The following is a description of a gene set: studied in species Homo sapiens The appearance of a cytokine due to biosynthesis or secretion following a cellular stimulus, resulting in an increase in its intracellular or extracellular levels. Human Gene Set: GOBP_CYTOKINE_PRODUCTION, and this is the list of marker genes: LILRA2, SMAD7, TRIM6, PRKD2, TRAF3, MIR100, FFAR2, CD226, MBP, TLR2, TRIL, TLR6, HLA-DPB1, CLNK, NRDC, SIGLEC1, ZBTB17 (NCBI Gene Id 7709), CARD16, GPR65 (G protein-coupled receptor 65), BANF1, PLAGL1, CACTIN, GLMN, MIR28, ARNT, NODAL (nodal growth differentiation factor), HMGB2, MIR19A, CD36, C5AR2, RELB, TYK2, CUL3, MIR302A, PTPN22, OTUD7B, CMA1, GBP1, TRIM15, IFNA2, IL4, TNFRSF21, IRF5, IL36A, FGFR1, ATF2, SCGB1A1, MIR204, ITGB6, CASP3, IFNGR1 (NCBI Gene Id 3459), HRAS, SPHK1, PTPRC, EZH2, CUEDC2, CLU, ARG2, MIR520C, IL2, NFATC4, APOA2, SMAD3, SIGLEC16, DDIT3, GSTP1, ALOX15B, SYT11, FFAR4, IKBKB, CEACAM20, DTX4, KAT2A, LAMTOR5, ILRUN, INAVA (innate immunity activator, NCBI Gene Id 91162), PRKCA, PANX2, RSAD2 (radical S-adenosyl methionine domain containing 2), OSM, POSTN, MIR520B, LRRC19, VTCN1, RARA, CYRIB, MIR185, HEG1, ELF4, MIR203A, NR1H4, TRAIP, MAVS, CD96, RNF216, ZFPM1, DDX1, PTGS2, LRRK2, MIR181D, MIR766, FN1, POMC, MIR26A1, NLRP7, GATA3, ZBTB45, IRAK3, TGFB3, CXCL6, PGLYRP3, ZNF287, EZR, DEFB131A, FCGR2C, KLF4, CARD9, MIR129-1, MIR130A, TICAM2, PANX3, MIRLET7C, NFKBIA, TLR7, RAET1G, BTNL10P, ADCY7, TNFRSF1B, VSIR, BTN2A2, NOS2, TSLP, UCN, MAPK14, PYDC2, LURAP1, CD81, CHID1, CD6, TRIB2, MIR214, TWSG1, NFKBIL1, CYLD, MIR24-1, ARHGEF2, IL17RB, IFNL1, TRIM56, AGT, HLA-DPA1, IRF4, AGER, KLHL22, MIR125B1, ADCYAP1, MAP2K5, BTK, CHRNA7, MIR194-1, MAPK9, ARRDC4, AZU1, NCKAP1L, C1QTNF3, INHA, MIR107, MIR488, ISL1, SMAD4, EIF2AK2, SRGN, RIPK2, CD83, LTF, HK1, HLA-B, AXL, CCDC88B, TRIM65, MIRLET7F1, C3, BMPR1A, S100A13 (S100 calcium binding protein A13), BCL10, TRAF3IP3, XCL1, PRKACA, FCGR2A, TIGIT, CD74, HOMER3, IL36RN, ZBTB14, HDAC3, MIR372, FCGR3A (Fc gamma receptor IIIa), ARRB2, JPH4, CD4, SERPINB1, REL, SPN, PHB1, CALHM6, JAK2, CLC, ZNF572, ARID5A, CREB1, MIR200B, ERBIN, HSPD1, MOG, AKAP8, STAT5B, LILRB1, CD2AP, HSPB1 (NCBI Gene Id 3315), IL6R, IRF8, IRGM, APOD, CGAS, LPL, RNF135, FZD5, TMIGD2, PER1, BST2, LACC1, PRG3, HLA-G, PLD3, IL18R1, RFTN1, AIM2, MIR365A (NCBI Gene Id 100126355), WNT5A, PDE4D, IL23R, FCER1G, MAST2, CD2, TNFSF4, FFAR1, FCGR1BP, IL9, TNFRSF8, SOCS5, GDF2, IL18, HSPA1B, THBS1, GPNMB, CYBA, PGLYRP2, MIR105-1, CD40, IL16, NLRC4, SULF2 (NCBI Gene Id 55959), MIR206, MALT1, IFNG, NLRP9, LGALS9B, PML, TUSC2, NOD2, CARD18, TNF, CRP, MIR146B, TIRAP, HMGB1, SPTBN1, MIR708 (NCBI Gene Id 100126333), LILRB2, LUM, PARK7, BCL6, GBP7, PNP, GATA4, CD200, ZCCHC3, PRKCQ, PELI1, IL1A, MIF, NOD1, GPAM, ACKR1, YY1, TRIM27, KPNA6, NMB, IL37, JAK3 (NCBI Gene Id 3718), SCAMP5, CEACAM1, MAPKBP1, FURIN, PIK3R1, HTR2A, USP22, IL5RA, IL33, MIR20A, F11R, PPP1R11, EBI3, CRLF2, NDFIP1, CCL19 (NCBI Gene Id 6363), HTR2B, ADIPOQ, EPHA2, ATF4, MIR149, HMSD, BCL6B (NCBI Gene Id 7613), IL17A, PLA2G3, IRAK1, WNT3A, TICAM1, MIR200C, UFSP2, MIR93, CRTAM, NR4A3, MIR34A, POLR3G, C1QBP, CLEC12A, ACE2, RIPK3, LEF1, PYDC1, IL1R2, BTN2A3P, TGFB2, BANK1, ZNF131, CD24, MIR411, UAP1, HSPA1A (NCBI Gene Id 3303), FLOT1, C5AR1, QKI, ANGPT1, TOMM70, ASB1, F2, ABCD2, ARG1, POLR3C, CCBE1, MIR145, ADRA2A, MEFV, CD160 (NCBI Gene Id 11126), MYD88, ZBTB25, NLRP2, MIR215, LRRC32, INHBA, SASH3, RIGI, OTUD5, HAVCR2, ITCH, GPR18, KLRK1, ZBTB32, LGR4, IGF1, LAPTM5, XBP1, IFIH1, NMBR, CXCL17, FOXJ1, CASP8, CCR2, CLEC5A, CRYBA1, BATF, MIR338, LEP, MIR29B1, NLRP12, IL13, PIK3CG, BCL3, TYROBP, CD28, FFAR3, RTN4, EIF2AK3, CD55, PLCG2, POLA1, KAT8, NFAM1, ZBTB7B, HDAC9, MIR106A, NOX5, TMF1, FGR, NPLOC4, AGPAT2, MIR205, LTB, NLRP6, DEFB114, TLR4 (toll like receptor 4), ZC3HAV1, LGALS9, CSF1R, CCR7, DENND1B, IL1RL1, IL1R1, NOX1, BTN1A1, SCIMP, PTPN6, ZBTB26, IL1RAP, ZBTB33 (zinc finger and BTB domain containing 33), NMI (NCBI Gene Id 9111), TRAF3IP1, NLRP2B, ADORA2B, STAT1, LTA, SCRIB, MAPK13, ARRB1, BTN3A1, IGF2BP3, NAIP, HLA-E, BTN3A2, RPS6KA4, LY9, ISG15, PYCARD, DEFB124, PTPRS, CHIA, SIRT1, HDAC2, ZBTB20, PGLYRP1, CD40LG, PTPN11, FERMT1, PKP3, PATZ1, IL12A, MERTK, LAPTM4B, MIR98, ZNF580, MIR101-1, AKAP12, STOML2, RUNX1, IL12RB1, TWIST1, ADAMTS3, RELA, MIR135A1, HLA-A, LITAFD, MAP3K7, FADD, IL1RL2, MUL1, TLR8, MIR106B, NLRP3, HLA-DRB1, FCGR1A, ORM1, IL26, CEBPB (CCAAT enhancer binding protein beta), RBX1, MYB, HGF, CD34, IGHD, MCOLN2, POU2AF1, PAEP, DLL1, WNT11 (Wnt family member 11), POLR3F, AKIRIN2, CD84, TRIM38, MORC3 (NCBI Gene Id 23515), CADM1, PLA2G1B, LITAF, ADAM17, UNC93B1, DDX56 (DEAD-box helicase 56), STMP1, CD3E, SORL1, SIRPA, MIR146A, STING1, FBLN1 (fibulin 1), RORA, ANXA1, ZC3H12A, AGPAT1, IL21 (interleukin 21), PPARA, EXTL3, AIF1, MIR373, APOA1, HDAC7, MIR182, MIR657, MIR19B1, MIR140, TGFB1, HYAL2, APPL2, TRIM16, OAS3, SETD2, G3BP1, IGF2BP2, MIR506, UBASH3A, N4BP1, SOCS1, PTGER4, CD86, TREM2, STAT3, HMOX1, HHLA2, BSG, POLR3B, MIR21, IL10, MIR27B, MIR125A, IL6, PDCD4, MIR222, PLA2G10, PTPRJ, UBA5, ADAM8, NLRP10, ABCC8, ZBTB2, TXK, SERPINF2, FXR1, PLA2R1, DDT, F2RL1, DHX33, PRNP, IL7, LAG3, ZBTB1, MMP8, OPA1, HOMER2, PDCD1LG2 (NCBI Gene Id 80380), MIR383, SLC2A10, BAP1, PIK3CD, CD7, NLRP1, GPR174, CHUK, ROCK2, PSG9, SEMA7A, PLD4, IL12RB2, CCL1, PDE4B, EOLA1, HSP90AA1, EGR1, BTNL9, RIOK3, IQGAP1 (IQ motif containing GTPase activating protein 1), GPATCH3, CAMK4, CSK, OAS2, SLC11A1, HMHB1, IL23A, MIR590, APP, TNFRSF14, KIT (KIT proto-oncogene, receptor tyrosine kinase), BTNL2, MIR15B, CD80, C3AR1, SERPINB7, MAPKAPK2, ALOX5, TRPV4, ATG9A, PSEN1, ATG12, C1QTNF4, SYK, ZBTB37, ARFGEF2, MIR17, USP50, INPP5D, NFKB1, CD14, LILRB4, SSC5D, CD276, IDO1, GHSR (growth hormone secretagogue receptor), UFD1, ABCD1, TSKU, CD46, ZNF683, CD58, TREX1, NLRC3, IFI16, SLAMF6, MIR324, CD244, CLEC6A, GAS6, MIR675, MIR16-1, MIR15A, RPS3, IL17RA, LILRA4, IRF1, ORM2, INHBB, TMED10, CX3CL1, SERPINE1, SPHK2, IKBKE (NCBI Gene Id 9641), POU2F2, ZP3, DHX58, CARD17P, MIR874, DEFA5, SECTM1, TBK1, GPSM3, IL32, TNFAIP3, HLA-F, SPON2, HFE, ERRFI1, MIR128-1, MIR361, MIR152 (NCBI Gene Id 406943), CCL3, BTNL8, MIR26B, PANX1, CASP1, GPRC5B, ELANE, SLAMF1, ZFP36, AIRE, INS, PIBF1, PQBP1, IL27RA, SPINK7, LGALS9C, CMKLR1, UBE2J1, DHX36, MIR197, MIR147A, KPNA2, MMP12, PPM1B, MIR31 (microRNA 31), CX3CR1, DHX9, CD274, ICOSLG, RNF26 (ring finger protein 26), RNF128, CARD8, TLR3, MIR504, HIF1A, MIR217, ACOD1, NDRG2, IL20RB, RAB7B, CR1, CD33, KAT5, HILPDA, ITK, MIR877, MIR195 (microRNA 195), SAA1, CLEC7A, CYBB, ZNF134, MIR20B, STAT5A, CLEC4A, MIR142, MC1R, CD47, KLF2, ERMAP, BTNL3, LY96, CARD11, APPL1, RAD21, IL15, ATP2B1, TLR1, S1PR3, GBA1 (NCBI Gene Id 82008), TIA1, CYP1B1, GARIN5A (golgi associated RAB2 interactor 5A), DRD2, LILRA5 (NCBI Gene Id 95091), IL4R, FCGR2B, IRF3, F2R, MAP2K3, GHRL, MIR132, RGCC, C5, LBP, ZBTB6, IL6ST, ZBTB39, HPSE, FOXP3, CLEC4E, CEBPG, CLEC9A, SELENOK, ACP5, MIR134 (microRNA 134), ZBTB49, MIR520H, MIR520G, FRMD8, MIR136, CLECL1P, EPX (eosinophil peroxidase), MIR155, IL17B, CHI3L1, CAPN2, RAB2B, TRIM21, IL17RC, EREG, MIR302D, HIC2, KIR2DL4, IFNB1, IL12B, PCSK5, ZBTB34, MIR935, MIR6869, MIR320A, SOD1, CD200R1, MIR181C (NCBI Gene Id 406957), RIPK1, MIR378A, HSF1, BTN2A1, DICER1, MIR181A2, MIR920, MACIR, RABGEF1, TRPM4 (transient receptor potential cation channel subfamily M member 4), MIR92A1, ZBTB12, IGF2BP1, ATG5, LYN, RBM47, ITGAV, MIR144, RAC1, CAMP, FCN1, PRKCZ, ANXA4, VSIG4, POLR3D, RPS6KA5, NPTN, XIAP, PF4, TRAF6, PRG2, EPHB2, TMEM106A, GATA6, DDX21, P2RX7, TBX21, TLR5, B2M, FLT4, KLRF2, DDX3X, ELF1, AFAP1L2, SULF1, F3, GAPDH, ADAM10 (ADAM metallopeptidase domain 10), BTN3A3, COL3A1, NLRX1, SELENOS, POLR3A, PLCB1, MIR221, SARS1, IL17F, RAB1A, IL1B, TRIM32, MIR199A1, SFTPD, IL17D, IL27, MDK, GSDMD, KLRC4-KLRK1, TANK, SIGIRR, SLC7A5, SETD4, CSF2, GIT1, BRCA1, RNF125, TSPO, IRF7, CCN4, MIR192, UFC1, TRAF2, FOXP1, TLR9, MAPK11, CPTP, NAV3, ABL1, CIDEA, MIR210, BPI, OAS1, ATP6AP2, CALCA, SNAI2, XAF1, MIR302C, GBP5